The following is a description of a gene set: Mouse Gene Set: MIR_2183 from publication Chen Y, Wang X (PMID 31504780) Genes predicted to be targets of miRBase v22 microRNA mmu_miR_2183 in miRDB v6.0 with MirTarget v4 prediction scores > 80 (high confidence targets). species: Mus musculus, and this is the list of marker genes: Kif5c, Ankfy1, Ergic1, Lrrc56, Rabgap1, Myo15a, Tab3, Nr3c2, Esp3, B230217C12Rik, Fer1l4, Faim (NCBI Gene Id 674737), Mybph, Mcpt4, Ccpg1, Timm8a1 (NCBI Gene Id 30058), Paqr5, Zfand2a, Setd1b, Sh2d3c, Hoxd11, Cux1, Carm1, Dhx15, Ctbp2, Cacfd1, Parp8, Erap1, Serf2, Gm57857, Nectin3, Marchf2, Cyp2c68, Cma2, Ube2d3, Ccnb1, Mxi1, Ppm1b, Sema6d, Bmp2, Tnrc6c, Msl3, Cnr2, B3galt6, Adck2, Lcn6, Ppm1k